The following is a description of a gene set: Human Gene Set: GOCC_VESICLE_MEMBRANE The lipid bilayer surrounding any membrane-bounded vesicle in the cell. species: Homo sapiens, and this is the list of marker genes: LRP2, SYT8, WASHC1, TAP2, MTMR4, RAB11A, EEF1AKMT4-ECE2, TBC1D5, STX12, SNX14, UNC13A, CC2D1A, MPEG1, SNX9, ACE2, HGS, RAP2C, PSEN1, ABCA3, DTX3L, SYT5, TAP1, ATP6V1H, GPR62, LDLRAP1, ABCC5, UEVLD, HLA-F, ARL8A, ECE2, SCARF1, SNX4, CLEC4D, SYPL1, CHMP1B, SNX19, ATP8A2, AGPAT2, STK10, RABEPK, GDE1, DOK3, STAM2, GJA1, GPR61, INSR, TMEM199, MCOLN2, PSENEN, MOXD2P, VPS28, ATP6V1E1, RAB5B, ACP3, HYAL3, LY6G6F, SLC18A2, SNAP25, TLR6, VPS37A, SEC23B, STAB2, WDR81, PRCP, SPRED2, CHRM2, NCKAP1L, GABRA2, WNT5B (NCBI Gene Id 84728), HLA-DMA, SLC17A9, RAB26, RAB5A (RAB5A, member RAS oncogene family), DNM1L, SLC17A7, PRRT1, SERPINA5, CLCN4, KCNAB2, ATP6V1D, SH3BP5, RAB11FIP1, BACE2, SV2B, MICAL1, MLANA, GLIPR1, CLTB, PLEKHF1, STEAP4, UBR4, MSR1, VTI1A, WLS, SPPL3, CYB561D2, ZFYVE28, SNX13, TBC1D3, SNX5, HMOX2, KIAA0319, MARCHF1, CEACAM8, SLC31A1, CACNG3, SAR1B, ATP6V1B1, RAB35, LHFPL2, TLR1, PRRT2, CFAP65, HVCN1, TAB2, GPER1, SLC26A7, FCMR, INPP5F, ANKFY1, NOSTRIN, TMEM106B, ANTXR2, ADGRE5, DIAPH3, SEMA4C, CKAP4, SNX8, RHOBTB1, APLP2, SCAP, RAB11FIP5 (RAB11 family interacting protein 5), CFTR, TYROBP, ABCA4, GNPNAT1, WDR91, DENND1A, SLC38A9, CEMIP, NRAS, MFSD12, SLC46A2, ZFYVE16 (zinc finger FYVE-type containing 16), LDLR, ATP6V0E1, TMEM179B, GAD1, STX1A, DIO3, HIP1, DSE, PACSIN2, RAC2, VAMP5, AP1S3, PDE6D, C2CD5, DYNLL1, MOXD1, WNT4, LAMTOR4, RAB27A, DSG1, TGOLN2, YIPF2, MVB12B, ATP6V0A2, PLAUR, IRAG2, MAGT1, CLCN6, SELP (NCBI Gene Id 6403), SLC35G2, VPS35, TRAF2, SLC18A3, RAB9B, ORMDL3, PTPRC, CD164, HLA-G, SPIRE2, TF, FLOT2 (NCBI Gene Id 2319), CLVS1, VPS35L, HBEGF, RAB11FIP3, SEC24D, CD1B, SNF8, STEAP2, SEPTIN8, NDFIP1, SYNDIG1, SEC13, RAB21, GOLIM4, CHMP5, DAGLA, WASHC5, CYBA, NUMB, SLC9A4, MYO5B, RHOU, PCSK4, VAPA, CHRNB4, CNGA4, APOB, SNX2, NECAP2, SLC29A3, ABCG4, SNX12, NRGN, SLC30A3, CD68, TRAF3, CUZD1, MOSPD2, VPS39, DRD2, TMBIM1, ANP32E, TMEM63A, AP3S2, VPS37D, APOE, ARPC2, ITM2B, SEC24B, GRIA3, OSBPL9, HSPA8, TRPM2, ITGA2B, GGA3, TOR1A, CPNE1, ABCC4, PLPP2, SLC18A1, CORO1C, LAMP5, IRF7, HLA-DRB1, PDLIM4, OTOF, TMEM165, ADAM30, FZD2 (frizzled class receptor 2), SERPINB6, SLC31A2, ABCA13, ATP11A, DLG4, SPPL2C, SH3GL2, MMD, TNFRSF1B, LAMTOR5, ANPEP, AP2B1, CLEC16A, CHMP2A, SLC9A7 (NCBI Gene Id 84679), ENPP4, SEC16B (NCBI Gene Id 89866), SEC31B, OSBPL11, TMEM175, FURIN, NCDN, KLHL12, AP2A2, ATG9A, PLIN3, SEC16A, RAB3B, AVP, ATP6V1G1 (ATPase H+ transporting V1 subunit G1), CD177, SYT2, P2RX1, IRAK2, FLRT1, STX4 (NCBI Gene Id 6810), GPNMB, CEACAM1, ASPSCR1, SNX3, CLIP1, LRP1, SLC15A3, EPN1, CYB561, CLIP3, SEC22B, SAR1A, ZFYVE27, SLC6A4, CD93, RAB15, WNT5A, CLCN5, ROR2, DMBT1, SNX17 (sorting nexin 17), AP2A1, TEPSIN, PIP4P2, GBP5, KDELR2 (KDEL endoplasmic reticulum protein retention receptor 2), HLA-DRB3, FCGR1BP, ANXA6, RHOB, ITGAV, ATP6V0B, CBARP, SEC23A, GBP7, CX3CR1, ANXA2, PHACTR2, MCFD2, SLC26A9, SNX20, CYB5R1, RAB44, TFRC, VAC14, NFAM1, SLC9A5, TLR8, PTPRS, ANXA7, DYSF, TAOK2, LLGL1, SCYL2 (SCY1 like pseudokinase 2), FRMPD3 (NCBI Gene Id 84443), CD109, GOSR2, SREBF2, RAB31, CPNE3, ANXA3, GBP2, DSP, DTNBP1, RAB3A, ATM, PTCH1, FLT3 (fms related receptor tyrosine kinase 3), CSPG5, TMC6, RAB4A, SYTL4, RAP1A, RHO (rhodopsin), AP3M1, SLC46A1, GRIA1, RAB22A, BAIAP2L2, AP3B2, BAIAP3, SLC4A11, INPP4A, ADRB2, CAMK2A, THSD1, PKD1, TMEM63B, WNT7B, ABCA5, CADPS2, ATP6V0A4, SYCN, TLR7, SLC45A2, TMED10, GAD2 (NCBI Gene Id 2572), DOC2A, LILRB2, SNX24, SLC6A2, VPS16, ZDHHC13, SCG3, OPRK1, CHMP6, SYT11, DCT, RAB11B, PIKFYVE, HLA-E, SLC4A8 (NCBI Gene Id 9498), PRKN, SGSM1, VPS53, SYNGR2, TRAF6, GRIN2A, TM9SF2, NOS3, TEKT3 (NCBI Gene Id 64518), ABHD17C, COPE, MS4A3, CNGB1, CD300A, CPE, BSN, RASSF9, MANBA, TSG101, NDUFC2, CD33, CD47, HLA-A, SNX18, MYO1B, OCRL, YIPF1, CHMP4A, IFNGR2, NDFIP2, MCTP1 (multiple C2 and transmembrane domain containing 1), ABHD17A, SCAMP4, CAV2, CD58, MVB12A, UBA52, SVOP, TRIM72, CHMP4B (charged multivesicular body protein 4B), SLC26A6, SPPL2B, SLC17A8, FCGR1A, CXCR1, PLA2G4B, SNAPIN, EGF, KIF1B, COPG1 (NCBI Gene Id 51137), ANTXR1, MITD1, CLCA1, CAMK2G, AQP5, SNX15, SIGLEC9, ARFGEF3, ATP6V0E2, SYT13, SLC9A9, SYNGR4 (synaptogyrin 4), SELL, PPT1, CTSD, SLC30A1, IYD, CALR, RAB9A, KIFC3, DYNC1LI1, APPL1, SLC30A10, SCAMP2, LNPEP, VMA21, RAB39B, TMEM59, PDIA3, COPZ2, ADGRE3, TMED7, HTR4, EEA1, OLR1, SNX1, SCYL1, EPGN (NCBI Gene Id 255324), HIP1R (huntingtin interacting protein 1 related), ADAM10, SEC23IP, SV2A, WDR83, PLA1A, SLC35F1, VTA1, ANXA8, CD53, RAB18, RNASEK, SLC9A8, RAB7B, HLA-H, HLA-DRA, CLN3, ZPLD1, SUN2, SIRPA, GAA, MAP6, AP1B1, VPS18, RIPK1, ARF6, LAMP1, HLA-DRB4, CD9, ABCA2, SNX33, RAP2A, SLC12A2, STEAP1, STAM, RAB13, LDLRAD4, EPS15, CHMP1A, CD74, SNX6, CNIH3, BACE1, PIGR, CD46, NPC1, SYNPR, ATP6V0D2, BST1, RAB8B, CD1C, PTPRJ, LAMP3, SCAMP3, GABRB2, SLC44A2, CLTC, VPS13C, CD8B, CHMP4BP1, SYPL2, ATP6V1F, SORCS2, ATP8B4, BORCS5 (BLOC-1 related complex subunit 5), WHAMM, RAB20, LAMTOR1, SYT12, RAB24, HLA-DOA, RHOQ, WASHC3, PKDREJ, SLC30A4, AREG, ANXA5, AP3D1, ITGB2, HLA-DQA2, COPB1, INPP5B, APH1A, SIGLEC5, RAB14, NTRK1, MKLN1, CNIH1, RAB6A, IQGAP1, TMEM9B, ABHD17B, GPRC5A, CRYZL2P-SEC16B, NSG1, SCAMP5, DIAPH1, MCOLN3, TMEM9, HLA-B, ANXA8L1, SLC9B2, CANX, ATP11C, AMPH, PI4K2B, ITPR3, ERBB2, RAB11FIP4, PKP1, STX6, AP5M1, LILRB3, ARHGAP32, ANXA10, MMP25, PMEPA1, CA4 (NCBI Gene Id 762), RAB11FIP2, SLC39A13, VPS13B, C3AR1, HLA-C, WDR44, HLA-DQB2, OSBPL6, VNN1, FMN2, KCNH1, ABHD6, AQP2, RAB1A, SYN1, CD55 (CD55 molecule (Cromer blood group)), RAB8A, FABP5, MREG, GIPC1, PLA2G4E, CDIP1 (cell death inducing p53 target 1), HLA-DPB1, SLC6A17, NOTCH1, TMEM190 (transmembrane protein 190), RAB43, SIGLEC14, PAM, AP1G1, LAIR1, ANXA9, CACNG8, TRIP11, PLEKHM1, STOML1, ABCA7, SCNN1B, DBNL, DSC1, UBA1, CSF3R, BIN1, LY96, TMEM67, STXBP5 (NCBI Gene Id 134957), HLA-DMB, CAMKV, ADAM8, SNX10, TMED3, RAB23, KIR2DL4, CHMP2B, ATG12, STX3, LAPTM4A, SURF4, CLEC4E (NCBI Gene Id 26253), CLEC12A, PLEKHB2, AGTRAP, ITGAX, ATG16L1, MDM2, ECE1, STX10, LILRA3, LZTR1, AQP11, SLA2, AP3M2, NSG2, SLC11A2, STX5, SBF2, EHD2, CR1, AP1G2, ATP11B, PEF1, BRI3, CD59, TMEM45B, CPTP, AP1S1, RHOA, ZG16, NDE1, APPBP2, GGA1, RHOD, SLCO4C1, RILP, IL15RA, CAMK2D, ARHGAP26, BECN1, VPS26A, SLC30A8, TBC1D24, VPS29, TLR3, DNAJC5, MYCBPAP, SNX21, GOPC, AQP6 (aquaporin 6), CMTM6, ZFYVE9, TMEM163, AVPR2, TOM1L1 (NCBI Gene Id 10040), FCGR3B, GPR135, BTC, ANXA11, LAPTM4B, SPAAR, TYRP1, IZUMO3, TAPBP, MARCHF11, ANXA2P2, SLC11A1, SLC9A6, STARD3NL, LYN, GRB2, GPRC5C, TPRG1L, CPLX3, TSPAN14, CD274, AZU1, RPH3AL, ATP6AP1, TRPM7, RAB27B, MYO1C (myosin IC), DBH, IFITM2, CHMP4C (NCBI Gene Id 92421), TEX101, FPR1, SAYSD1, GPR151, CLVS2 (clavesin 2), TH, RABGEF1, HTT, RAB5C, UBAP1, COLEC12, VPS36, ATP8A1, AP1S2, MYO6 (NCBI Gene Id 4646), WIPI1, VPS4A, VPS37B, B4GALT1, EHD1, CLTCL1, PGRMC1, VAMP1, CACNG4, RALA, IGF2R, RNF13, SERPINB12, CACNG2, TSPAN15, SLC18B1, APP, DCSTAMP, ATG5, ITPR1, IQGAP2, AP2S1, SPACA6, SNTB2, NCSTN, MICALL1, FCAR, VPS45, EHD4, ARCN1, TMEM225, RABEP1, RNF167, VPS33B, SYNJ1, VAMP7, BTBD8, IRGM (NCBI Gene Id 345611), SPACA3, DNAJC13, CALM3, AQP7, WASL, PI4K2A, CNGA2, IRAK4, SYT6, ACAP2, GBP1, CD36, TMEM108, CALY, STX17, SLC39A14, IRAK1, LPCAT1, WNT7A, FER1L5, EPHA4, NFASC, COPZ1, ZNRF1, MR1, FZD7, SLC30A2, SEC24C, NCL, GPR65, SLC15A4, WASH3P, VAMP4, ATAD3B, IL7R (interleukin 7 receptor), KCNJ4, SYT3 (NCBI Gene Id 84258), ATP6V1G3, KIF16B, CHMP3, MCOLN1, RFFL, SLC17A5, WNT3A, B2M, RMC1, BST2, VOPP1, LRP6, LRIG3, ANXA13, AP3S1, SLC35D3, ATP10B, AFTPH, SPHK1, TMEM95, GABRG2, FCGR2A, OPRD1, ITCH, CD1D, SYN3 (NCBI Gene Id 8224), WNT3 (NCBI Gene Id 7473), RHOF, GPR161, ATP6V0C, CLTA, COPG2 (COPI coat complex subunit gamma 2), HPS6, SPIRE1, SYT4, SEC31A, TAB3, TLR2, FFAR4, GPR143, SH3GL1, MGST1, MARCHF2, CD207, RIPOR1, CYB561A3, PHAF1, SEC24A, TMEM30A, EHD3, HLA-DPA1, RAP1B, HLA-DQB1 (major histocompatibility complex, class II, DQ beta 1), ACAP1, BCL2L1, OPTN, RAB32, EPHA8, ENTHD1, FGD2, STOM, FAM170B, FPR2, SRI, GABARAPL1, SLC5A7, STXBP2, KIF1A, LAMP2, FIG4, VPS41, PIP4P1, SNX16 (NCBI Gene Id 64089), TARM1, SLC2A4, STEAP3, ABCC8, ARC, DGKI (NCBI Gene Id 9162), SYP, TGFA, GRIPAP1, AP3B1, SLC48A1, SLC28A2, MME, ARHGAP1, SLC32A1, SNCA, SH3KBP1, MON2, SYN2, ATP13A4, ENTREP1, NMNAT2, TOM1, ANKRD27, MMGT1, SNAP29, FZD5, SNX30, CD14, STK26 (serine/threonine kinase 26), UNC13B, ULK2, NCK2, PMEL, DISP3, GRIA2, ELAPOR1, USO1, SCARB1, APPL2, IZUMO1, SNX27, PML, SCARB2, ITGAM, SV2C, MARCO, SMO, AMN, GGA2, MFGE8, SORL1, DIPK2A, CD300LG (NCBI Gene Id 146894), EREG, ARHGAP21, CLEC10A, ITGAL, SLC36A2, SLC2A3, ATP13A5, KDELR1, APH1B, CD63, DENND4C, KDELR3, STX7, ADGRG3, TICAM2, CAV1, CLEC4C, UBC, ENTPD7, MYD88, FNDC3A (fibronectin type III domain containing 3A), LEPROT, PTPRB, ATP6V1C1, KREMEN2, VPS52, RAB34, VTI1B, CYBB, ATP6V1A, ATG9B, CLBA1, MAP3K7, EPHB1, MFSD8, SPG21, VPS33A, DGAT1, AKAP5, STON2, RET, ITGB1, BSG, ATP2B1, CD44, STX16, RAB39A, REEP6, EQTN, EGFR, ZDHHC1, FOLR1, PDCD6, SCAMP1, RHOBTB2, ABCC11 (ATP binding cassette subfamily C member 11), RPS27A, CLCN3, TRARG1, SYT9, VPS13A, RHOV, RAB4B, ATP6V1B2, FCGRT, ATP8B3, M6PR (mannose-6-phosphate receptor, cation dependent), SNAP23, NCALD, SLC1A1, NCF4, PACSIN1, SLC9A3, PTPRN, TYR, C5AR1, LITAF, RNF144A, DNM2, HLA-DQA1, NPC1L1, TPCN2, KCNQ1, CADPS, SLC2A5, TMEM150B, TPCN1, HLA-DRB5, ICA1, ABCB11, STING1, SCGN, RAB10, CEACAM6, DEGS1, PECAM1, DDOST, ARL8B, MFSD10, NBEAL2, VPS4B, LRRK2, SNX7, RAB17, ANXA4, ATP13A3, REP15, WASHC4, PIK3R4, GPR89A, USP8, VPS25 (NCBI Gene Id 84313), LAMTOR2, SIRPB1, RAB38, ALDH3B1, ATP13A2, MCEMP1 (NCBI Gene Id 199675), TLR4, DAB2, ABCB6, RPH3A, PHF24, PLEKHF2, RCC2, MARCHF3, NECAP1, ZDHHC11, ZPBP, STAB1, VPS37C, PTAFR, ATP6AP2, DGKQ, IFITM3, SMAGP, FZD4, CXCR2, KCNK6, ZNRF2, TMED2, SYNGR1, PIP5K1C, SPACA4, CD3G, MYOF, GP2, GRB14, ZDHHC17 (zinc finger DHHC-type palmitoyltransferase 17), SVIP, HGSNAT, KIF13A, WASHC2A, MALRD1, GIMAP5, FCER1G, NTRK2, WNT1, ATP6V0D1, STARD3, TCIRG1, MARCHF8, RAB7A, CTNS, CEACAM3, CD163, LAMTOR3, ATP9A, GPR18, MAPKAP1, SPNS2, ITGB3, VAMP2, PICK1, COPB2, RAB12, SYNRG, ITPR2, UBE2D3, WNT6, WFS1, GABRA1, RAB3D, RAP2B, OR51E2, PNLIPRP2, SPPL2A, MLEC, RND2, ARHGAP10, MRC1, DMXL2, DOP1B, PLD3, DCST1, PARM1, WASHC2C, TBC1D10C, TMEM184A, TAB1, TAFA4, RAC1, PLAU, VAMP8, STBD1, BOK, RUFY1, TMX3, ARRB1 (arrestin beta 1), YKT6, MTMR2, CD1A, SNX25, SORT1, DKK1 (dickkopf WNT signaling pathway inhibitor 1), CORO1A, STON1, SGIP1, PRAF2, NDRG1, COPA, CLIC4, CD4, TASL, SYNGR3, AP5S1, HSD17B6, CD3D, OCA2, UBB, PLD1, GABRB3, PCDH7, ARRB2, WAS, PKD2, MCTP2, SYT10, NAPEPLD, FZD6, RAB37, GPRC5B, EPN2, ACRBP, RBSN, TLR9 (NCBI Gene Id 54106), VAMP3, TICAM1, ANO6, GRIA4, UBAP1L (NCBI Gene Id 651364), ADCY8, CLEC5A, SLC17A6, UNC13C, SERPINB10, AP1M1, SREBF1, ZMPSTE24, DCST2, NCK1, HLA-DOB, UBXN6, COMMD1, CLINT1, EPN3, EXOC3, LITAFD, CNIH2, SYT7, CHMP7, LMAN1, SLC27A2, ZDHHC2, NEU3, PSAP, GPR84, SLC30A5, AP2M1, CCDC136, SLC39A4, TNK2, SLC2A8 (NCBI Gene Id 29988), SLC15A2, B4GALNT2, SNX22, PI4KA, PTPRN2, SYT1, PIK3C3, WASH6P, PLEKHM2, AP4B1, SPARC, SH3GL3, LGALS3, MGAM, ATP6V0A1, AQP4, GALNTL5, PCSK9, ANXA1, AP1M2, CYSTM1, CAMK2B, SPACA1, ATP6V1G2, ATP7A, CIDEB (NCBI Gene Id 27141), CC2D1B, ABCA12, VPS11, SLC6A9, RHOG